The following is a description of a gene set: from publication Amit I, Garber M, Chevrier N, Leite AP, Donner Y, Eisenhaure T, Guttman M, Grenier JK, Li W, Zuk O, Schubert LA, Birditt B, Shay T, Goren A, Zhang X, Smith Z, Deering R, McDonald RC, Cabili M, Bernstein BE, Rinn JL, Meissner A, Root DE, Hacohen N, Regev A (PMID 19729616) Human Gene Set: GSE17721_CPG_VS_GARDIQUIMOD_6H_BMDC_DN Genes down-regulated in comparison of dendritic cells (DC) stimulated with CpG DNA (TLR9 agonist) at 6 h versus DC cells stimulated with Gardiquimod (TLR7 agonist) at 6 h. studied in species Homo sapiens mouse primary BMDCs were stimulated with tlr ligands and gene expression changes were profiled on Affymetrix arrays, and this is the list of marker genes: EN2, MSL3, SPECC1, GK, PCNX3, SDC1, ERP44, NFYA, SVIL, PBXIP1, TRMT2A, SARS1, ZNF704, CPSF1, MCUB, SNX18, GRSF1, TAFAZZIN, DPAGT1, FLCN, LMBR1, IFI30, MAT2A, PYCR1, ABHD4, DGAT1, TIMM8A, DIPK2A, PPM1G, TPP2, TNK2, TMBIM1, CHD8, ZC3H18, HSD17B12, PDE8A, AKAP10, GCLC, CASP6, SIRPA, AIFM1, SNX12, WDR6, RSPRY1, CNIH1, RIPK1, UTP20, IPPK, MIA3, RYK, SPRYD7, BCAP29, UQCRB (NCBI Gene Id 7381), NEU1, ZNF639, CIAO3, LUC7L, LRRK1 (leucine rich repeat kinase 1), CSNK1G1, UGGT2, HIVEP1, SLAIN2, LIMD2, TMCO1, MED24, RPIA (NCBI Gene Id 22934), TNFRSF4, SAE1, IRF3, TM2D2, JAK2 (NCBI Gene Id 3717), MFSD1, IMP4, NAP1L5, TP53RK, ALG9, DERL2, GIPC1, NRDC, SEC11A, ZC3H12C, UBE2A, NRDE2, BATF3, RIBC1, WDR75, KLHL42, CAD, KCTD12, TSPAN13 (tetraspanin 13), XPR1 (xenotropic and polytropic retrovirus receptor 1), HMGCS2, ADSS2 (adenylosuccinate synthase 2), TCN2, RNF130, STK38, CRHR2, NANS (NCBI Gene Id 54187), IL36A, GYG1, NADK, POFUT2, PACRGL, NBR1, CLNS1A, SNF8, RNF128, FZD1, METTL3, NSUN2, TLE6, MPND, LPCAT3, TNFRSF9, SLC4A8, PPP4R3B, MYO1F, S100PBP, TRMT44, KCTD1, DHX40, TLR2, LIMD1, SRP54 (signal recognition particle 54), SYNGR2, ERLIN1, EEF1E1, TFPI, CMTM3, MMS22L, MBD3, CFP, ARMC6, CER1, SUSD2, LCN2, MR1 (major histocompatibility complex, class I-related), PARL, FGF13, RDH10, NUP107, TF, COL8A1, UCK2, VOPP1, NCBP1, INTS6L, PON2, PRKAG2, PRPF3, SMC2, POLR3F, AHDC1, ADIPOR2, SYNJ2, LPGAT1 (NCBI Gene Id 9926), AKR1B15, PPBP, HSPA9, ZBTB20, USP11, HDGF, USP33, ETS2, LSM2, PSMG1, TTC13, SNRK, C5orf24, SLC30A5, NUMB, MVP, UPF3B, ETFDH, USP34, TBP, NLRP3, CRY1, SCYL1, HSPA5, TMEFF1, MET, RGL2, EI24, PRAF2, TMEM185A, PTGES, TCEAL8, INSIG2, WAS, SPINT2, PLEKHA1, ST7L, CEP55, FICD, THAP12, SREBF2, MAP2K3, GNL3, GAR1